The following is a description of a gene set: species: Mus musculus Mouse Gene Set: GOMF_APOLIPOPROTEIN_RECEPTOR_BINDING Binding to an apolipoprotein receptor., and this is the list of marker genes: Nr1h2, Kif5c, Pcsk9, Abca12, Cdc42, Apoa2, Apoa1